The following is a description of a gene set: Allergic rhinitis species: Homo sapiens Human Gene Set: HP_ALLERGIC_RHINITIS It is characterized by one or more symptoms including sneezing, itching, nasal congestion, and rhinorrhea., and this is the list of marker genes: SIK3, CDSN, CARMIL2, KRT74, PLCG2, COX4I2, PGM3, CPN1, DOCK8, SLC27A4, IGKC, IGHG2, SPINK5